The following is a description of a gene set: Human Gene Set: HP_ACCELERATED_ATHEROSCLEROSIS Accelerated atherosclerosis studied in species Homo sapiens Atherosclerosis which occurs in a person with certain risk factors (e.g., SLE, diabetes, smoking, hypertension, hypercholesterolaemia, family history of early heart disease) at an earlier age than would occur in another person without those risk factors., and this is the list of marker genes: CYP7A1, APOE, XYLT1, CELA2A, LMNA, ABCC6, ABCA1, XYLT2